Given this list of marker genes Cyp1a1, Cyp2f2, Cyp2j11, Cyp2c40, Cyp4f18, Cyp2j6, Cyp4a12a, Cyp2b9, Cyp2j8, Cyp2a12, Cyp2c54, Cyp4a14, Cyp4a31, Cyp2a5, Cyp2j7, Cyp2e1, Cyp4a10, Cyp2j12, Cyp2t4, Cyp4a29, Cyp2c29, Cyp4f40, Cyp2c39, Cyp2c66, Cyp2j9, Cyp2j5, Cyp4f14, Cyp4a30b, Cyp2b13, Cyp2s1, Cyp2a22, Cyp2b23, Cyp2j13, Cyp2a4, Cyp4a32, Cyp2c38, Cyp4f15, Cyp2c55, Cyp2c50, Cyp2b10, Cyp4a12b, Cyp2d22, Cyp2c37, Cyp2g1, Cyp2c65, Cyp2b19, Cyp2c23, here is a description of the gene set: Mouse Gene Set: GOMF_ARACHIDONATE_MONOOXYGENASE_ACTIVITY studied in species Mus musculus Catalysis of the incorporation of one atom from molecular oxygen into arachidonic acid and the reduction of the other atom of oxygen to water.